The following is a description of a gene set: Reactome Pathway: Free fatty acids regulate insulin secretion part of: Regulation of insulin secretion Free fatty acids augment the glucose-triggered secretion of insulin. The augmentation is believed to be due to the additive effects of the activation of the free fatty acid receptor 1 (FFAR1 or GPR40) and the metabolism of free fatty acids within the pancreatic beta cell. This module describes each pathway. studied in species Homo sapiens, and this is the list of marker genes: GNAQ, CD36, PLCB1, ACSL4, PLCB3, GNA14, FFAR1, GNA11, ACSL3, PLCB2, GNA15